Given this list of marker genes Entpd4b, Cda, Dctd, Stpg4, Dpysl2, Upb1, Entpd5, Aicda, Dut, Entpd4, Nt5c, Dpys, Dctpp1, Nt5m, Dpysl5, Pycr3, Crmp1, Dpyd, Entpd7, Dpysl4, Dpysl3, Upp2, Cdadc1, Aldh6a1, Nt5c3, Upp1, Tymp, here is a description of the gene set: species: Mus musculus The chemical reactions and pathways resulting in the breakdown of a pyrimidine-containing compound, i.e. any compound that contains pyrimidine or a formal derivative thereof. Mouse Gene Set: GOBP_PYRIMIDINE_CONTAINING_COMPOUND_CATABOLIC_PROCESS